Given this list of marker genes ATP6V0C, CLCA3P, FZD2, FBXO24, SGCA, NRL, MAP1B, ZNF428, DOK3, FAM117A, ZFY, ITPR3, RAB6C, CCDC122, ANG, SLC24A3, NRAS, CCDC80, GDNF, GCM1, PRICKLE2, HIVEP3, TP53INP2, MTUS1, SKIDA1, POU3F4 (POU class 3 homeobox 4), BZW2, CSF3, PPP2R3A, ST13P4, CCND1, ROBO3, HDAC9, ARHGAP4, GPRC5B, CD79B, TRAF3IP2 (NCBI Gene Id 25997), CNOT2, LINC00470, MIR17HG, PROKR2, TRDN, BCORP1, SCRN1, BMP5, ENAM, DNAH5, SOX5, GPR4 (G protein-coupled receptor 4), FOXN1 (NCBI Gene Id 8456), H2AC21, MYF5, CRISP1, NONO, EGR2, ITGB3BP, AKT1S1, CRYZL1, BCOR, OTX2, NPHP4, POU2F3, OPA3, RXFP1, KCNN3, CUX1 (NCBI Gene Id 1523), TAS1R2, JUND, HOXA5, ATP1B2, MED16, TSC22D3 (TSC22 domain family member 3), SH3GL3, CCDC107, ZEB2 (zinc finger E-box binding homeobox 2), PHC2, GRID2, CES5A, HOXB4 (homeobox B4), RFTN2, DPYSL3, TAS2R7, PRDM10, ADGRL1, LLGL2, TRERF1, RAB5A, PLCB2, PCYT1B, KANSL1L, HOXC5, C2CD2L, SREBF2 (NCBI Gene Id 6721), H2BC21, CACFD1, DCUN1D3, TMSB4XP4, PTEN, NEUROG1, GPR22, MAF, PANK4, PRDM1, UPK3A, DLG2, LRRN1, THRA, CHD6, SUCNR1, PIPOX, DLX1, NPTX2, EYA1, NUFIP2, NEK10, EMILIN3, CCDC6, SEMA6C, CCN1, NRXN1, PCDH20, SESN3, FOXB1, RHOB, NFIA, DLGAP4, YWHAB, CUL3, NAP1L5, BACE2, FGF12, BEX3, TEC, MMP1, HOXB1, CELSR2, MSI2, CDK2, ATOH1, MMP17, HOXB6, MBNL2, IL25, PRRC2A, H2BC4, HPCAL4, PHF6, PDZK1IP1, LINC01164, HOXC11, TCF4, ITSN1, SALL1, RNASE4, OR10A5, H2AC20, CA13, LHX6, IRX4, TRPS1 (NCBI Gene Id 7227), PIM2, SP6, CSRNP3, KCNIP4, NEIL3, IL1RAPL1, ADGRV1, ZNF804B, ANKMY2, TOP1, SFRP1, GPR85, NKX2-2, NRXN3, REL, SLC10A2, CADM2, SPIB, POU1F1, ALDH1A1, EDA, UQCC2, RAB26, ADM, ZFX, PDZD2, BST2, MIR9-1HG, RRAS, SORBS1, H2BC3, SYNPR, UTP18, CBFA2T2, LIPG, E2F3, TBXAS1, TLX3, ACTG2, ABTB2, RAB3C, H2AC12, GBX2, PFKFB1, TBC1D17, TTI2, KCNT2, ADORA2A, ORAI3, CADM1, TCERG1L, LACC1, SCOC, SH3BGRL, LHX3, AMBN, EIF1AX, EPC1, GPC4, RANBP3L (NCBI Gene Id 202151), LYN (NCBI Gene Id 4067), CCDC116, ERG, KCTD4, PRR34, FCHSD1, MCC, NR6A1 (NCBI Gene Id 2649), LMO3, CLVS1, ARHGEF12, IRAK1, SFRP2, WNT9A, STRN4, LCOR, TFAP2C, ADNP2, EML1, POLM, SMARCA1, SYT1, PMEL (premelanosome protein), VPREB3, HOXA10, ISL1, PRRX1 (NCBI Gene Id 5396), H3C3, CACNG2, PITX2, CSMD3, COL23A1, ITPRIP, ATF7IP, DGKG, H2BC12, BRINP3, RARB, TUBB4A, FOXG1, HOXA3, ALK, KCTD6, TAS2R13 (taste 2 receptor member 13), SLC17A7, NR4A3, MRAS, ALDH1A2, IRX5, ANK3, SNCAIP, DNAH7, LYRM1, PCDH8, KRT28, EPCIP, UBE2S, CD180, SALL3, SRF, ACBD4, TNNI1, TSNAX (translin associated factor X), ADNP, TSC1, NIN (ninein), HNF1B, ENOX1, HOXD9, CAMKV, PAX6, CHAT, SEMA7A, ETV1, REST, PATZ1, SPATA31H1, DLL1, MRFAP1, LDHAL6B, SLC25A12, NPR3, WWC2-AS2, CDK14, NUDT6, C12orf57, NUDT3, SCAF4, FGF20, STRIP1, SLC18A3, STMN1, ASXL1, SERTAD4, MAB21L2, FKRP, LRCH4, DLL4, SIAH3 (siah E3 ubiquitin protein ligase family member 3), LDB2, AKT2, ZHX2, DLL3, HOXA7, EGLN2, ING1, SASH1, SLC6A15, PIWIL4, DUSP10, H3-3B, ESRRA, H2AC6, SEPTIN9, GRIN3A, NEDD4, COL25A1, LETM2, ATXN7L1, ADORA1, MID1, REM2, GNB3, RCAN1, ID2, XYLT2, DCN, HOXD11, LPL, MAGEE2, WNT6, NXPH1, UCMA, LMO4, BARHL2, PDZRN4, FOXP1 (forkhead box P1), ARMH4, EPHB3, IL17F, PLPPR2, TSPAN13, LRFN5, NOS1 (NCBI Gene Id 4842), HEPACAM, FZD4, C2CD5, here is a description of the gene set: species: Homo sapiens Comprehensive identification of all functional elements encoded in the human genome is a fundamental need in biomedical research. Here, we present a comparative analysis of the human, mouse, rat and dog genomes to create a systematic catalogue of common regulatory motifs in promoters and 3' untranslated regions (3' UTRs). The promoter analysis yields 174 candidate motifs, including most previously known transcription-factor binding sites and 105 new motifs. The 3'-UTR analysis yields 106 motifs likely to be involved in post-transcriptional regulation. Nearly one-half are associated with microRNAs (miRNAs), leading to the discovery of many new miRNA genes and their likely target genes. Our results suggest that previous estimates of the number of human miRNA genes were low, and that miRNAs regulate at least 20% of human genes. The overall results provide a systematic view of gene regulation in the human, which will be refined as additional mammalian genomes become available. Genes having at least one occurrence of the highly conserved motif M44 YATGNWAAT in the regions spanning 4 kb centered on their transcription starting sites. This matches the transcription factor binding site V$OCT_C (v7.4 TRANSFAC). from publication Xie X, Lu J, Kulbokas EJ, Golub TR, Mootha V, Lindblad-Toh K, Lander ES, Kellis M (PMID 15735639) Human Gene Set: YATGNWAAT_OCT_C